The following is a description of a gene set: Breast cancer patients with the same stage of disease can have markedly different treatment responses and overall outcome. The strongest predictors for metastases (for example, lymph node status and histological grade) fail to classify accurately breast tumours according to their clinical behaviour. Chemotherapy or hormonal therapy reduces the risk of distant metastases by approximately one-third; however, 70-80% of patients receiving this treatment would have survived without it. None of the signatures of breast cancer gene expression reported to date allow for patient-tailored therapy strategies. Here we used DNA microarray analysis on primary breast tumours of 117 young patients, and applied supervised classification to identify a gene expression signature strongly predictive of a short interval to distant metastases ('poor prognosis' signature) in patients without tumour cells in local lymph nodes at diagnosis (lymph node negative). In addition, we established a signature that identifies tumours of BRCA1 carriers. The poor prognosis signature consists of genes regulating cell cycle, invasion, metastasis and angiogenesis. This gene expression profile will outperform all currently used clinical parameters in predicting disease outcome. Our findings provide a strategy to select patients who would benefit from adjuvant therapy. Human Gene Set: VANTVEER_BREAST_CANCER_METASTASIS_UP Genes whose expression is significantly and positively correlated with poor breast cancer clinical outcome (defined as developing distant metastases in less than 5 years). from publication van 't Veer LJ, Dai H, van de Vijver MJ, He YD, Hart AA, Mao M, Peterse HL, van der Kooy K, Marton MJ, Witteveen AT, Schreiber GJ, Kerkhoven RM, Roberts C, Linsley PS, Bernards R, Friend SH (PMID 11823860) species: Homo sapiens, and this is the list of marker genes: RAB27B, SEC14L2, SPEF1, PDIA4, EVL, FBP1, STK32B, MS4A7, QDPR, MYLIP, KIF3B, GSTM3, ALDH6A1, RBP3, MYRIP, EBF4, NEO1, TBX3, FUT8, BTG2, RPS4X, CIRBP (NCBI Gene Id 1153), ECI2, PCSK6, BBC3, MATN3, FGF18, SCUBE2, TGFB3, ERGIC1, AP2B1, LAMP5, CHPT1, ELAPOR1, ALDH4A1, KIAA1217, TBC1D9, CCDC74B, KRT18 (keratin 18), INPP5J, CCN4, PEX12, IP6K2, ACADS, LETMD1